Given this list of marker genes Slc6a3, Osbpl8, Kcnh1, Kcnmb2, Itpr1, Scn4a, Best2, Abca8a, Kcnv2, Trpv6, Trpv1, Faim2, Ank, Slc17a1, Gabrd, Trpc1, Npc1l1, Kcnc1, Slc1a4, Clca3a1, Magt1, Cnnm4, Cav3, Slc22a29, Slc5a1, Ndufv1, Slc17a4, Scnn1a, Pex14, Gje1, Cideb, Slc25a4, Grin2a, Slc39a4, Grik2, Tmem63b (transmembrane protein 63b), Bcl2a1d, Oscp1, Slc10a6, Gjb4, Mip, Tmbim7, Ttpa, Cacnb1, Tmprss3, Tmed10-ps, Atg5lrt, Gabrr3, Calm2, Slc10a4-ps, Slc1a6, Lrg1, Tmem168, Hvcn1, Slc6a20a, Ano5, Sfxn2, Cnga2 (cyclic nucleotide gated channel alpha 2), Hamp2, Itpr2, Slc26a7, Gsdmc4, Mfsd12, Slc4a2, Slc39a2, Slc35b1, Slc4a11, Bloc1s3, Kcnf1, Slc16a10, Trpc7 (transient receptor potential cation channel, subfamily C, member 7), Prelid3a, Timm17b, Trpm1, Nipa2, Calm1, Atp5pd, Kcnmb1, Psen1, Ndufs1, Ano7, Gpld1, Akt1, Slc25a42, Cplx3, Lrrc8c, Gabra5, Apoa2, Atp11a, Tnni3, Trpm2, Cacnb2, Scn1a, Slc26a10, Chrna5, Ghitm, Slc5a2, Stim2, Kcnh5, Gja3, Slc17a3, Gabre, Gabra6, Slco2a1, Abca13, Otop2, Kcnk5, Abcg3, Atp9a, Slc35e2, Slc4a5, Ano10, Atp13a1, Kcnn3, Gabrb2, Aqp2, Abca12, Asic2, Slc22a22, Calhm1, Slc37a2, Slc25a32, Micu2, Gramd1b, Tpcn2, Surf1, Slc2a7, Hpx, Chrnb1, Mpc1, Itgav, Cidea, Slc23a2, Xkr4, Letm2, Kcnq2, Aqp8, Tmbim6, Slc10a5, Slc9a9, Slc25a18, Slc19a2, Slc20a1, Slco1b2, Kcnc4, Cacng2, Kcna7, Catsper3, Kcnj10, Aqp11, Slc7a4, Xpr1, Kcnv1, Slc38a1, Slc9b2, Kcnk3, Slc4a9, Slc13a3, Gabra2, Akap9, Stard3, Slc22a16, Slc13a1, Slc36a2, Pctp, Atp7a, Slc35e3 (NCBI Gene Id 77205), Slc6a7, Slc7a9, Slco1a7, Kcnj3, Chrna3, Atp8b2, Cyb561d2, Abcb9, Cacna1f, Slc16a7, Kcnt2, Slc5a4b, Grik4, Ano3, Cnih2, Slc7a5, Slc7a6, Nipa1, Slco1a4, Abca3, Slc48a1, Orai3, Trpm7, Vti1b, Nedd4l, Clca4a, Pias3, Uqcrh (NCBI Gene Id 78331), Slc25a51, Stom, Clcn1, Fxyd5, Clic4, Trpv3, Slc45a4, Abca9, Ipo8, mt-Nd2, Apol9a, Tmem135, Tmem184a, Stard5, Slc2a1, Slc38a6, Orai1, Aqp12, Slc25a27, Mpc2, P2rx4, Aqp9, Kcnj11, Slc49a3, Abcg1, Cdh17, Rrad, Gjb2, Slc26a11, Slc7a13, Atg9b, Kcna1, Prf1, Slc15a5, Otop3, Slc51b, Gpm6a, Bltp1, Cacna2d4, Bcl2a1b, Abcg5, Vmp1, Prkcz, Slc35a5, Slc22a20, Sv2a, Dpp6, Mfsd2a, Slc35f2, Abca14, Slc2a10, Stra6l, Slc25a17, Sec61a1 (SEC61 translocon subunit alpha 1), Scn2a (sodium channel, voltage-gated, type II, alpha), Aqp6, Sec61a2, Gpihbp1, Cacna1a, Clcn5, Slc31a2, Commd1, Vdac1, C2cd2l, Cabp1, Kcnab1, Slco1a6 (NCBI Gene Id 73773), Cacna1e, Fabp1, Kcnk15, Trpv4, Slc39a9, Abca7, Atp1a3, Scn1b, Slc24a1, Clca3b, Cptp (NCBI Gene Id 79554), Abca6, Plekha8, Kcnd3, Tmem175, Panx3, Lrrc52, Nrxn1, Rasa3, Bcl2a1a, Slc25a24, Tmbim4, Cachd1, Atp5me, Catsper1, Clcn3, Glra1, Atp1a2, mt-Nd5, mt-Co3, Tmc1, Nipal1, Cyb561a3, Slc5a10, Fxyd4, Osbpl5, Plscr1l1, Nherf1, mt-Cytb, Slc28a2b, Slc22a3, Atp6v0a2, Calhm4, Slc39a13, Tspo2, Atp6v1a, Ndufa10, Rack1, Slc6a8, Kcnk7, Atp6v1c2, Tmem109, Lynx1, Slc44a5, Slc26a1, Slc26a6, Abcc10, Gltpd2, Trpc4, Atp6v1e1, Osbpl3, Adrb2, Asic5, Tnfaip8l3, Pdzd11, Lrp2, Slc43a1, Bcl2l2, Amigo1, Slc50a1, Pcsk9, Slc25a29, Tmbim1, Sumo1, Slc27a2, Sorl1, Slc22a18, Slc52a3, Slc16a9, Slc9a8, Grm7, Atraid, Trpm6, Slc12a8, Slc41a3, Gsdmc2, Scn8a, Snca, Glrx, Atp9b, Cidec, Atp5f1b, mt-Nd4l, Slc25a10, Snf8, Cacna1i, Cacna2d1, Atp6v0a4, Tmc8, Atp2a3, Slc16a11, Kcnn2, Slc39a6, Cyc1, Lamp2, Cnih3, Star, Slc29a4, Trpv5, Agt, Tfrc, Slc12a4, Slc4a3, Gjb3, Atp8b1, Pex1, Grik3, Slc30a10, Slc38a9, Slc22a30, Bcl2, Atp4a (ATPase, H+/K+ exchanging, gastric, alpha polypeptide), Ccdc51, Cftr, Ucp3, Gm5134, Lamp1, Cldn10, Slc36a4, Lasp1, Cldn16, Slc15a3, Tmem144, Tmem184b, Gabrp, Slc44a4, Abcd4, Slc15a4, Rem1, P2rx1, Slc46a1, Slc12a9, Clic3, Slc30a2, Gjd4, Slc25a22, Kcnk13, Pgrmc2, Kcnmb4, Abca8b, Atp2a1, Plscr4, Slc19a3, Gpr89, Panx2, Slc29a3, Pltp, Gabrg1, Anxa5, Abcc4, Abcc8, Slc16a12, Nalf2, Kcne4, Kcnn1, Scn3a, Osbpl6, Cacng3, Kcnk9, Gsdme, Cnga4, Slc36a1, Cldn19, Slc5a9, Apom, Gsdma3, Slc27a6, Grin1, Atp6v0d2, Catsper2, Slc22a27, Clic6, Best3, Ndufs8, Cacnb3, Gabra4, Atp5mf, Kcnh7, P2rx3, Gpd1l, P2rx6, Kcnk16, Glra4, Spns1, Kcnq1, Mfsd3, Ano1, Ywhah, Gjb6, Slc6a17, Clca4b, Pkd2l1, Tmem44, Atp13a3, Slc25a36, Atp10d, Slc25a2, Slc4a4, Kcna2, Gabrq, Ndufs7, Mcu, Slc44a3, Slc22a6, mt-Co1, Slc25a3, Ttyh2, Slco6d1, Wnk4, Slc44a1, Slc25a14 (NCBI Gene Id 20523), Slc30a4, Tomm20, Nrxn2, Kcnj14, Clcn2, Htr3a, Slc25a26, Slc39a7, mt-Atp8, Ensa, Fkbp1a, Slco3a1, Slc39a1, Slc17a7, Slc22a7, Mmgt2, Kcna6 (potassium voltage-gated channel, shaker-related, subfamily, member 6), Slc26a8, Slc16a13, Gabrg2, Trpv2, Abcc12, Fabp4, Atp2b4, Gramd1c, Chrne, Abcd2, Sidt2, Pkd2l2, Slc25a47, Slc15a2, Kcnk10, Abcc1, Slc35f6, Slc45a1, Mcoln3, Slc12a1, Slc7a14, Cacng8, P2rx2, Slc6a5, Ryr2 (NCBI Gene Id 77553), Slc22a14, Grik5, Nalcn (sodium leak channel, non-selective), Cacng4, Atp6v0b, Kcng2, Cox7a1, Trpm4, Aqp5, Cldn15, Slc35b4, Cnnm3, Ano2, Htr3b, Rbp4, Slc25a5, Lmbrd1, Abcg4, Sgk1, Slc1a3, Slc8b1, Shoc2, Ano9, Plscr3, Bnip1 (BCL2/adenovirus E1B interacting protein 1), Mcl1, mt-Nd3, Mcoln2, Slc6a2, Slc7a2 (NCBI Gene Id 11988), Slc38a5, Nnt, Atp4b (NCBI Gene Id 11945), Pex5l, Nedd4, Cabp5, Slc35c2, Mfsd10, Slco1c1, Pkd2, Atp6ap1, Gja4, Fabp2, Slc25a12, Cacng1, Atp8b3, Hcn2, Slc9a5, Abcg2, Slc25a37, Fabp3, Fxyd2, Atp6v0e, Vamp8, Atp10b, Slc25a1, Cacna1d, Kcnq4, Tap2, Spns3 (NCBI Gene Id 77577), Slc22a2, Slc38a4, Slc5a6, Slc39a3, Slc45a2 (solute carrier family 45, member 2), Slc25a41, Chrnb4, Grin2c, Camk2d, Rhd, Catsper4, Tmem150c, Abca17, Kcng1, Slc17a8 (solute carrier family 17 (sodium-dependent inorganic phosphate cotransporter), member 8), Stoml1, Slc2a6, Trpm8, Ptpn3, Slc25a21, Kcna5, Ndufs2, Slc26a3, Flna, Bcl2l1, Atp5mc3, Slc24a3, Gria4, Lrrc8d, Slc47a2, Osbp, Htr1b, Tmc6, Wnk2, Atp2b2, Slc35e1, Tusc3 (tumor suppressor candidate 3), Chrna7, Slc38a11, Ryr1, Kcnk1, Stim1, Atg2a, Slc25a19 (solute carrier family 25 (mitochondrial thiamine pyrophosphate carrier), member 19), Atp2c2, Mcoln1, Slc16a1, Slc28a2, Gabrr1, Tmem63a, Kcnj1, Rem2, Uqcrh-ps1, Slc18b1, Mfsd4a, Fabp5, Stard4, Bok, Cox4i2 (cytochrome c oxidase subunit 4I2), Kcna10, Sec61g, Slc16a6, Slc10a7, Glra2, Clcn7, Kcnt1, Dpp10, Slc2a3 (solute carrier family 2 (facilitated glucose transporter), member 3), Kcns2, Trpm3, Stra6, Slc14a2, Pex6, Stimate, Rimbp2, Atp1a1, Chrna1, Stx1a, Slc6a11, Slc14a1, Clcn6, Slc28a1 (solute carrier family 28 (sodium-coupled nucleoside transporter), member 1), Slc30a9 (NCBI Gene Id 76440), Slc35c1, Tomm70a, Clcnkb, Nos1, Slc44a2, Chrnd, Ano8, Tmem241, Fxyd3, Abcb5 (ATP-binding cassette, sub-family B member 5), Sgk3, Slco2b1, Kcnj4 (NCBI Gene Id 16520), Mfsd8, Atp13a2, Scn10a, Vdac2, Svopl, Trpa1, Tmem94, Kcng3, Slc16a8, Slc17a9, Chrnb3, P2rx5, Rtbdn, Tmc7, Timm23, Kcnc2, Atp5po, Slc39a14, Piezo1, Slc16a4, Slc9c1, Atp6v1g3, Gltp (glycolipid transfer protein), Apol10b, Atp11c, Gsdma, Apoe, Slco5a1, Stx8, Slc66a1, Slc17a6, Grina, Scnn1b (sodium channel, nonvoltage-gated 1 beta), Tmem120a, Bltp3b, Cacna1s, Tspan13, Slc22a4, Gabrr2, Atp6v1c1, Abca15, Kcna3, Fxyd6, Kcnh8, Slc17a5, Kcnk18, Osbpl2, Bcs1l, Ceacam1, Pfpl (NCBI Gene Id 56093), Slc6a13, Wnk1, Atp2a2, Atp2b1, Slc10a2, Slc13a2, Cybrd1, Atp6-ps, Gjc3, Sting1 (stimulator of interferon response cGAMP interactor 1), Pkd1, Serinc5, Pitpna (NCBI Gene Id 18738), Kcnn4, Dlg1, Slc35a4, Slc5a3, Kcnip4, Actb, Slc2a12, Phpt1, Kcnj16, Romo1, Slc6a14, Nrxn3, Piezo2, Atp6v0d1, Ttyh1, Clca2, Slc35b2, Atp6v0a1, Gjb1, Slc10a1, Tmem184c, Slc7a11, Slc25a11, Atp6v1e2, Afg3l2, Slc30a5, Atp6v0e2, Cox5a, Slc46a3, Trpc5, Slc51a, Slc25a16, Slc26a9, Pitpnm3, Panx1, Atg2b, Slc1a1, Tpcn1, Gria1, Cldn17, Kcns3, Crisp4, Pitpnm2, Slc26a4, Pex13, Ank2, Slc29a1, Cd44, Slc19a1, Cacna2d2, Gjd2, Atp12a, Slc5a7, Cldn4, Cabp4, Slc2a2, Nmur2, Slc3a2, Clcc1, Aqp7, Slc8a2, Cngb3, Apol8, Slc2a13, Atp8b5, Slc24a2, Tmem266, Timm17a, Bcl2a1c, Slc12a2, Smdt1, Atp5f1e, Gja6, Gga3, Atp2c1 (NCBI Gene Id 76638), Slc35a2, Arpp19, Slc25a45, Slc29a2, Slc36a3 (solute carrier family 36 (proton/amino acid symporter), member 3, NCBI Gene Id 215332), Gja10, Kcnj5, Slc30a6, Slc8a3, Spns2, Gnb2, Slc28a3, Slc1a7, Atp13a5, Kcnu1, mt-Nd1, Gjb5, Slc9a7 (solute carrier family 9 (sodium/hydrogen exchanger), member 7), Gsdma2, Slc25a38, Kcnip1, Kcnb1, Slc22a13 (NCBI Gene Id 102570), P2rx7, Slc22a21, Slc6a12, Grik1, Calhm3, Rhbg, Fgf14, Slc31a1, Slc25a30, Kcnc3, Atp11b, Slco4a1, Cngb1, Clca1, Abcg8, mt-Atp6, Grin3a, Apol9b, Plscr5, Tmc5, Slc27a1, Slc2a8, Clic5, Hamp, Slc25a25, Kcna4, Wnk3, Scn2b, Bax, Mfsd14a, Kcnj9, Mpv17, Abcd1, Slc22a15, Slc16a2, Atp7b, Atp1b2, Atp5f1c, Atp5pf, Gc, Slc46a2, Kcnip3, Slc16a14, Gja1 (gap junction protein, alpha 1), Hnrnpa3 (heterogeneous nuclear ribonucleoprotein A3), Slco6c1, Slc33a1, Npc2, Fxyd1, Tap1, Slc7a1, Gja5, Ndufs3, Slc35d3, Kcns1, Slc1a5, Nipal4, Slc34a2, Cd36, Atp5mc2, Lrp6, Ctns, Cert1, Scn7a, Kcng4, Kcnk6, Slc4a1, Sfxn4, Asic4, Cpox, Fgf11 (NCBI Gene Id 14166), Pkd1l2, Calhm6, Tmed10, Cacna1g, Grid1, Slc43a3, Apob, Nipal2, Slc18a3, Abca2, Slc7a10, Slc24a4 (solute carrier family 24 (sodium/potassium/calcium exchanger), member 4), Atp6v1b1, Slc18a2, Ndufv2, Atg9a (NCBI Gene Id 98551), Calhm5, Tmem30b, Sv2b, Micu3 (NCBI Gene Id 78506), Mfsd2b (MFSD2 lysolipid transporter B, sphingolipid), Lrrc8a, Abcc9, Slc25a54, Nipal3, Atp5mc1 (ATP synthase membrane subunit c locus 1), Slc12a7, Slc39a12, Ano6, Kcnj12, Abcc3, Slc16a5, Slc35a3, Mttp, Slc22a19, Gjc2, Pkd1l3, Gabra1, Gem, Kcnd2, Slc26a2, Kcnb2, Mpeg1, Slc27a4, Flvcr1, Itpr3, Ndufs4, Chrm5 (cholinergic receptor, muscarinic 5), Oprm1, Ralbp1, Tmem37, Gja8, Slc7a7, Kcnk12, Hcn1, Slc25a20, Kcnh3, Scn5a, Gabrg3, Slc39a10, Hrh1, Slc39a8, Atp2b3, Sec63, Slc9a3 (solute carrier family 9 (sodium/hydrogen exchanger), member 3), Kcnab2, Slc11a1, Anxa6, Slco1a1, Lrrc8b, Pitpnc1, Atp6v0c, Slc25a15, Cldn2, Serinc3, Gria2, Triap1, Atp6v1f, Clic1, Slc2a9, Kcnip2, Prkcb, Afg3l1, Prkg1 (protein kinase, cGMP-dependent, type I), Gsdmc3, Calhm2, Slc6a20b, Abca4, Prelid2, Calm3, Slc22a12, mt-Nd6, Slc47a1, Tomm40l (translocase of outer mitochondrial membrane 40-like), Slc7a8, Fgf13, Atp5f1d, mt-Nd4, Bak1, Atad1, Vdac3 (NCBI Gene Id 22335), Slc6a15, Ryr3, Mrs2, Kcnj6, Tomm40, Atp1b3, Tmco1, Gsdmc, Cybb, Kcne3, Abca16, Cav1, Kcnh2, Slc10a3, Slc6a18, Fxyd7, Tmem120b, Glrb, Atp8b4, Ndufa2, Prss30, Slc43a2, Nat3, Mmgt1, Lrrc26, Timm29, Kcne1, Plscr2, Gabra3, Esyt1, Tmc3 (transmembrane channel-like gene family 3), Slco1a8, Slc35d1, Slc11a2, Zdhhc13, Slc22a23, Slc34a3, Gsdmd, Pitpnm1, Atp1a4, Otop1, Slc6a6, Clptm1l, Slc4a7, Mlc1, Chrnb2, Grid2, Uqcrfs1, Slc32a1, Kcnk2, Asic1, Slc12a3, Npc1, Slc22a28, Kcne5, Slc35d2, Ttyh3, Gjc1, Micu1, Tomm22, Slc5a5, Glra3, Slco4c1, Slc41a1, Chrna6, Slc7a15, Apol10a, Chrna4, Slc6a19, Pdpn, Aqp3, Gabrb1, Scp2, Letm1, Lrrc55, Slc23a3, Apoa5, Slc13a4, Cnnm2, Ucp2, Cacna1h, Chrna10, Aqp1, Slc23a1, Prss8, Slc22a1, Tmco3 (NCBI Gene Id 97481), Hcn4, Slc35f1, Orai2, Apol11b, Chrna2, Prelid1, Slc26a5, Scn9a, Slc20a2, Slc9a6, Pkdrej, Slc2a5 (solute carrier family 2 (facilitated glucose transporter), member 5), Slc22a17, Slc37a4, Slc25a31, Slc25a44, Slc22a8, Aqp4, Atp5mg, Trpm5, Slc37a3, Mfsd4b1, Cyb561d1, Tmem165, Slc25a28, Chrng, Slc34a1, Slc25a39, Timm22, Oca2, Clcn4, Cacnb4, Abcb1b, Pacc1, Kcnh4, Slc12a6, Grm2, Asic3, Slc25a13, Plscr1, Slc5a4a, Slc38a3, Sfxn3, Igf1r, Kcnj8 (potassium inwardly-rectifying channel, subfamily J, member 8), Sclt1, Ndufb7, Slc30a8, Mfsd14b, Mcub, Slc13a5, Slc41a2, Nalf1, Best1, Tspoap1, Sfxn1, Slc10a4, Trpc6 (NCBI Gene Id 22068), Atp6v1g1, Slc30a1, Serinc2, Kcnj15, Abcb7, Atp5pb, Tmem30a, Gjd3, Mfsd4b5, Kcnq5, Chp1, Abcb4, Abca5, Flvcr2, Scn4b, Bsnd, Kcnj2, Abcc5, Fkbp1b, Slc9a2, Abcb11, Abca1, Slc25a23, Rhcg, Abcb1a, Grin2b, Pde4d, Slc25a33, Clcnka, Fgf12, Slc18a1, Kcnj13, Apoa1, Rangrf, Abcc2, Mfsd9, Grin3b, Slc15a1, Apol11a, Ncs1, Tmem41b, Scn11a, Slc35b3, Sv2c, Snta1, Cacng7, Stx7, Ucp1, Slc25a48, Sidt1, Slc4a10, Pitpnb, Tmc4, Slc38a8, Abcb10, S100a6, Xkr8, Scnn1g, Kcne2, Gm2a, Clca3a2, Tomm20l, Tmem63c, Mfsd1, Slc40a1, Ano4, Xkr9, Slc38a2, Slc39a11, Slc22a26, Atp6v1d, Slc45a3, Trpc2, Grin2d, Bcl2l10, Rhag, Slc30a7, Cacna1b, Cacng5, Gria3, Slc16a3, Slc30a3, Kcnh6, Atp1b1, Svop, Slc52a2, Kcnk4, Kcnab3, Tmem38b, Slc4a8, Gabrb3 (NCBI Gene Id 14402), Atp5f1a, Abcb6, Kcnq3, Ceacam2, Slc38a10, Slc24a5, Kcnma1, Abcb8, Cacng6, Pou2f2, Pacsin3, Tmc2, Slc12a5, Slc39a5, Slc6a4, Slc5a12, Atp8a1, Sfxn5, Slc22a5, Slc5a8, Trpc3, Slco1a5, Chrna9 (cholinergic receptor, nicotinic, alpha polypeptide 9), Slc7a12, Sgk2, Slc37a1, Lrrc38, Hpcal4, Cnga3, Gramd1a, Slc6a1, Slc38a7 (NCBI Gene Id 234595), Abcc6, Slc7a3, Prelid3b, Cacna1c, Snap25, Slc27a5, Atp13a4, Slc9a1, Ywhae, Hcn3, Scn3b, Slc25a53, Slc35a1, Mfsd5, Slco6b1, Tmem38a, Atp10a, Slc5a11, AU018091, Slc1a2, Unc80, Slc9b1, Atp6v1g2 (NCBI Gene Id 66237), Atp8a2, Apoa4, Cnga1, Cabp2, Abcd3, Cnnm1, Pkd1l1, Cacna2d3, mt-Co2, Atp6v1b2, Lrrc8e, Kcnmb3, Slc35e4, Atp6v1h, Slc25a40, Slc8a1, Slc9a4, Slc6a9, Slc2a4, Kcnd1, Slc17a2, Grm3 (NCBI Gene Id 70346), here is a description of the gene set: Mouse Gene Set: GOMF_TRANSPORTER_ACTIVITY studied in species Mus musculus Enables the directed movement of substances (such as macromolecules, small molecules, ions) into, out of or within a cell, accross or in between cells.